Given this list of marker genes Mafg, Arhgef2, Pcdha7, Cramp1, D7Ertd443e (DNA segment, Chr 7, ERATO Doi 443, expressed), Phospho2, Scn1a, Slc17a6, Fyn, Cd164, Dyrk1b, Pheta2, Pcdha6, Cdh2, Rbmyf9, Pcdha9, Rfx3, Cxcr5, Tmigd1, Tafa1, Ube2g1, Pdgfrb, Ptp4a1, Ifi47, Rbmyf8, Pcdha4, Zbtb4, Pcdha1, Zmym2, Gpr155, Ncald, Ube2d2a, Ptpn13, Ppp3ca, Lyrm4, Bahd1, Lrit2, Scml4, Rbmy, Enpp2, Mboat1, Plppr4, Itga1, Magohb, Pcdha12, Traip, Zfp42, Fth1, Rbmyf3, Scn3a, Parp4, Dsc2, Prkaa2, Slc6a18, Slco1b2, Mpp3 (membrane protein, palmitoylated 3 (MAGUK p55 subfamily member 3)), Pcdha11, Pcdha5, Mcmbp, Galntl6, Prorsd1, Prkra, Pafah1b1, Zfp930, Rbmyf2, Pcdha10, Crebrf, Scn2a, Slc5a3, Rbmyf1, Pcdha2, Slc34a1, Ccdc120, Tmem179b, Car12 (NCBI Gene Id 76459), Rbmyf7, Copb1, Plpp2, Six1, Pcdhac1, Pnn, Slc38a2 (NCBI Gene Id 67760), Dyrk1a, Zfp217, Mafb, Tmem150a, Dnaja3, Bdnf, Tab3, Adcy2, Samhd1, Pcdhac2, Arhgap24, Igf1, Klf4, Trpa1, Crxos, Pcdha3, Abce1, Pde8b, Dennd4c (DENN domain containing 4C), Slc25a26, Rbmyf5, Ptgfrn, Arhgap6, Pik3r3, Adam12, Ctr9, Ccdc88a, Pcdha8, Xrn1, Wdr44, here is a description of the gene set: from publication Chen Y, Wang X (PMID 31504780) Genes predicted to be targets of miRBase v22 microRNA mmu_miR_150_3p in miRDB v6.0 with MirTarget v4 prediction scores > 80 (high confidence targets). Mouse Gene Set: MIR_150_3P studied in species Mus musculus